Given this list of marker genes Tnfsf4, H2-T23, Il1rap, Syk, Havcr2, Cd3e, Ddit3, Nlrp3, Icosl, Cebpb, Ndfip1, Mir301, Sash3, Prkcz, Zp3, Rara, Foxp3, Cd83, Lef1, Slc7a5, Cd28, Irf4, Scgb1a1, Zfpm1, Gata3, Cd40lg, Fcer1g, Prkcq, Epx, Il20rb, Cd1d1, Il33, Cd1d2 (NCBI Gene Id 12480), Prg2, here is a description of the gene set: Any process that modulates the frequency, rate, or extent of interleukin-4 production. species: Mus musculus Mouse Gene Set: GOBP_REGULATION_OF_INTERLEUKIN_4_PRODUCTION